The following is a description of a gene set: Mouse Gene Set: MIR_7233_3P from publication Chen Y, Wang X (PMID 31504780) studied in species Mus musculus Genes predicted to be targets of miRBase v22 microRNA mmu_miR_7233_3p in miRDB v6.0 with MirTarget v4 prediction scores > 80 (high confidence targets)., and this is the list of marker genes: Dapk1, Tent5a, Elk3, Hemgn, Uchl5, Lnx1, Strn3, Cdk12, Itgb1bp1 (integrin beta 1 binding protein 1), Mecom, Tll1, Gnao1, Timm17a, Scube2, Chpt1, Tmprss11g, Tsc22d2, Sec61a2, Whamm (WAS protein homolog associated with actin, golgi membranes and microtubules), Rpl5, Itsn2, Grip1, Rfx7, Sox14, Atp2b2, Dzip3, Pdp1, Fut9, Tspan12, Fbxo3, Cpxm2, Sdk1, Dok5, Mfsd1, Erbin, Prps2, Kcnh8, Myh10, Cdkn1b, Copg1, Plekha6, Grsf1, Scd3, Zfp516, Sec24a, Snrk, Spata31d1c, Nipa2, Stx18, Srgap1, Slc39a10, Lrrtm4, Chsy3, Laptm4a, Angel2, Ddit4l, Zeb2, Lamp2, Foxj3, Pacrg, Nr5a2, Rsrc2, Slk, Sh3d19, Ppig, Ube3a, Lpl, Gnal, Thrb, Pld5, Mlxip, Trmt11, Cdc37l1, Tra2b, Sirt1, Ccdc141, Ago2 (argonaute RISC catalytic subunit 2), Topors, Eya3